The following is a description of a gene set: A reduction in the activity of the mitochondrial respiratory chain complex III, which is part of the electron transport chain in mitochondria. Decreased activity of mitochondrial complex III studied in species Homo sapiens Human Gene Set: HP_DECREASED_ACTIVITY_OF_MITOCHONDRIAL_COMPLEX_III, and this is the list of marker genes: GATC, RARS2, DGUOK, ATP5F1A, TSFM, MRPS14, NSUN3, QRSL1, AGK, UQCC3, MTO1, UQCRH, MPV17, CHCHD10, MRPS16, UQCRQ, ISCU, BOLA3, MRPS22, CARS2, COQ4, EARS2, C1QBP, TIMM22 (NCBI Gene Id 95988), GFM2, GFM1, CRLS1, NDUFS4, TK2, YARS2 (NCBI Gene Id 51067), TAMM41, BCS1L, SUCLG1, LYRM7, UQCC2, CYC1, MIEF2, FBXL4, TRMT5, TRMT10C, NFS1, MT-TL1, TTC19, UQCRB, TXN2, SLC25A4